Given this list of marker genes MAP4K5, GLS, TNFRSF10A, DYNLT1, HLA-DRA, PAX8, HLA-DRB6, NLRC3 (NCBI Gene Id 197358), TSPYL1, RAB18, KRBOX1, NECTIN3, HLA-DPB1, SFXN2, PPP2R2A, RALA, MFSD2A, TMEM207, STAT2, MYDGF, APOL6, MDGA1, FBXO6, CCL20, IRAK1, IL1B, HLA-DRB1, MYO1E, MYCL, IFRD1, RSAD2, SERPINB2, DPH3, SAMD9L, EAF1, RGMB, PLAUR, BTN3A1, LRRC4C, PLEKHN1, ERAP2, STAP2, KCNK5, IRF7, ARHGAP15, UPB1, HELZ2, SS18L2, CASP4LP, LCN12 (NCBI Gene Id 286256), RXRG, TMEM87A, ADCY5, INHBA, CST13P, RBCK1, PSMA2, MMADHC, EIF1, NSUN2, EPSTI1, GBP5, GBP1, NXT2, IQCH, PSMB8, F2R, HLA-A, BCL7B, POMP, KCNJ6, C12orf42, ADM, PARP14, TRIM21, HLA-DPA1, PCDHB6, CCDC180, BFSP2-AS1, STAT1, NSUN3, SCML1, EPYC, PPP3R2, TNF, TAP1, BNIPL, NLRC5, PSMA3, TRAV8-3, DNAJA1 (NCBI Gene Id 4737), PSMB9, GNPDA2, ERO1A, LINC00842, CASP1, ARTN, SLC39A11, LINC00205, LGALS3BP, MYT1, STING1, DNAJB11, IGF2BP3, KLHL10, LINC02297, BDNF-AS, MR1, IRF1, MTHFD2L, DDX60L (NCBI Gene Id 91351), HCAR3, CENPJ, STX3, CDC42EP3, MYOF, BTN3A2, CARD6, BCL2A1, GBP4, HLA-B, ZNF276, DYNC1H1, APOL1, SIPA1L1, HRK (NCBI Gene Id 8739), GIMAP8, STARD8, DECR1, HLA-DQA1, TMEM39A, CSF2, NFE4, CFAP46, RGS17, SP140L, CD74, DUSP5, SECTM1, KHNYN, LRRC77P, C21orf91, HSPA4L, WARS1, CREM, RNF149, STARD4, PSME2, ORC6, NDUFA10, EREG, RAB4B, MFAP5, ZBTB7C-AS2, RAPSN, UBE2L6, LINC00851 (NCBI Gene Id 440757), PNMA8B, VPS9D1, CALHM6, TAFA5, PLAAT4, LINC00639, RTP4, GPR174, PSMA5, IQGAP2, EIF2B2, ENSG00000230725, IL12RB1, PLEKHO1, HLA-E, SCARF1, CEP290, HINT1, PNP, PTGS2 (NCBI Gene Id 5743), EIF2S2, LYNX1, HLA-DQB1, AMN1, BRDT, SLC2A3, USP15, RIMKLB, KL, POLB, TMCO2, SLC5A9, SSR3, CFAP161, CXCL2, FAM161A, here is a description of the gene set: Type I IFN-inducible gene expression in human blood monocytes primed with Type II IFN. from publication Tassiulas I, Hu X, Ho H, Kashyap Y, Paik P, Hu Y, Lowell CA, Ivashkiv LB (PMID 15467722) species: Homo sapiens Genes down-regulated in monocyte-derived macrophages: untreated versus stimulated by interferon alpha. Human Gene Set: GSE1740_UNSTIM_VS_IFNA_STIMULATED_MCSF_DERIVED_MACROPHAGE_DN